Given this list of marker genes FOS, SERPINA3 (serpin family A member 3), LOX, DUSP1, SERPIND1, LCN2, LITAF, ANGPTL4, NDUFS1, NFKBIA, OR4E1, PLA2G7, RBM3, KLF6, CSTB, SLFN12, NR4A1, CDKN1A, TNC, SFN, AKAP12, MCL1, ELN, RETNLB, CCN1, MYC, TPM1, STEAP4, S100A8, PTX3, SPHK1, SPP1, TGFBI, EIF1AY, LTBP1, TXNRD1, BTG2, FCGR2A, KLHL2, COL3A1, ZFP36, MAL, LTF, LRG1, PTGES, OSMR, here is a description of the gene set: studied in species Mus musculus The role of nitric oxide (NO) in acute lung injury remains controversial. Although inhaled NO increases oxygenation in clinical trials, inhibiting NO-synthase (NOS) can be protective. To examine the latter, nickel-exposed mice were treated with saline or NOS inhibitor, N(G)-nitro-L-arginine methyl ester (L-NAME). Initial microarray analysis of nickel-induced gene expression of saline-treated mice revealed increased inflammatory mediator, matrix injury-repair, and hypoxia-induced factor-mediated sequences and decreased lung-specific (e.g., surfactant-associated protein B and C) sequences. Compared with saline control, L-NAME-treated mice had enhanced survival with attenuated serum nitrate/nitrite, endothelial NOS activity, and lavage neutrophils and protein. Although initial cytokine (i.e., interferon-gamma, interleukins-1beta and -6, macrophage inflammatory protein-2, monocyte chemotactic protein-1, and tumor necrosis factor-alpha) gene expression was similar between groups, subsequent larger cytokine increases only occurred in saline-treated mice. Similarly, surfactant protein gene expression decreased initially in both groups yet was restored subsequently with L-NAME treatment. Interestingly, the role of inducible NOS (iNOS) in these responses seems minimal. iNOS gene expression was unaltered, iNOS activity and nitrotyrosine residues were undetectable, and an iNOS antagonist, aminoguanidine, failed to increase survival. Rather, systemic L-NAME treatment appears to attenuate pulmonary endothelial NOS activity, subsequent cytokine expression, inflammation, and protein permeability, and thereby restores surfactant gene expression and increases survival. Genes up-regulated in the mouse model of acute lung injury induced by inhaling nickel sulfate. from publication McDowell SA, Gammon K, Zingarelli B, Bachurski CJ, Aronow BJ, Prows DR, Leikauf GD (PMID 12540486) Human Gene Set: MCDOWELL_ACUTE_LUNG_INJURY_UP